Given this list of marker genes Stat1, Pax2, Osr1, Wnt4, Tcf21, here is a description of the gene set: The process in which relatively unspecialized cells acquire specialized structural and/or functional features that characterize the mesenchymal cells of the metanephros as it progresses from its formation to the mature state. Mouse Gene Set: GOBP_METANEPHRIC_MESENCHYMAL_CELL_DIFFERENTIATION studied in species Mus musculus